The following is a description of a gene set: part of: G1/S Transition electronically inferred by orthology from the curated human pathway This event has been computationally inferred from an event that has been demonstrated in another species.<p>The inference is based on the homology mapping from PANTHER. Briefly, reactions for which all involved PhysicalEntities (in input, output and catalyst) have a mapped orthologue/paralogue (for complexes at least 75% of components must have a mapping) are inferred to the other species. Reactome Pathway: Cyclin E associated events during G1/S transition species: Mus musculus, and this is the list of marker genes: Psma1 (proteasome subunit alpha 1), Cdkn1b, Psma2, Ubb, Psmc2, Psma5, Ccnh, Ccne1, Cdkn1a, Psma6, Ccnd1, Psmc6, Psmb5, Psmd12, Psmd6, Psmc4, Psma7, Psma4, Wee1, Cdk4, Psma3, Psmd13, Psmc3, Psmc1, Psmd7, Cul1, Cables1, Psmd1, Rb1, Psmb4, Ccne2, Psmb6, Rps27a, Psmc5, Psmb7, Ccna1